Given this list of marker genes FGF6, RASSF7, SSH1, PAK4, CHRM2, VCL, FGF14, MYH10, MOS, MRAS, FGF13, BDKRB2, PIP4K2C, FGF21, FGF18, CHRM4, PIK3CD, MYL3, TMSB4X, PDGFRB, SOS1, PIP5KL1, SOS2, SSH3, PIP4K2A (NCBI Gene Id 5305), PAK1, RAC3, PIP5K1C, RRAS, WAS, KRAS, FGF8, MYLK, DIAPH3, MAP2K1, EZR, NRAS, RDX, ARHGEF7, PIK3R3 (phosphoinositide-3-kinase regulatory subunit 3), FGF20, CYFIP2, CFL1, PDGFB, CHRM5, ROCK2, ACTG1 (actin gamma 1), FGF17, MAPK1 (NCBI Gene Id 5594), ROCK1, ARHGAP35, PIK3R2, APC, WASF2, PAK3, PDGFRA, PIK3CG, VIL1, FGF4, GNA13, RAC1, PIK3R1 (phosphoinositide-3-kinase regulatory subunit 1), FGF5, GSN, PIK3CA, FGFR3, FGF10, PAK5, BDKRB1, WASF1, BRK1, CFL2, FGF3 (fibroblast growth factor 3), RAF1, RAC2, F2, GNA12, BAIAP2, FGF23, FGF22, CHRM1, FGD1, PXN, PIK3C2A, FGF16, ARHGEF1, CRK, FN1, NCKAP1, FGFR2, PIK3C2B, CHRM3, ACTB, PIP5K1A, CD14, MAP2K2, FGF1, GNG12, APC2, ENAH, PIK3CB, ARHGEF6, PTK2, PIK3C3, MAPK6 (NCBI Gene Id 5597), PAK6, F2R, BCAR1, CSK, EGF (epidermal growth factor), BUB1B-PAK6, FGF11, PFN1, FGF2, PDGFA, GIT1, PIK3R5 (NCBI Gene Id 23533), MSN (moesin), MAPK4, PAK2, DOCK1, PPP1R12A, IQGAP1, RRAS2, FGF12, PIK3C2G, ACTN1, PIP4K2B, FGFR4, SSH2, ARPC5, RHOA, ARHGEF4, PIK3R4 (phosphoinositide-3-kinase regulatory subunit 4), MAPK3, FGF19, FGFR1, PIP5K1B, LIMK1, CDC42, SLC9A1, FGF7, DIAPH1, VAV1, ITGA1, MYL1, FGF9, BRAF, ABI2, EGFR, here is a description of the gene set: Human Gene Set: WP_REGULATION_OF_ACTIN_CYTOSKELETON Regulation of actin cytoskeleton studied in species Homo sapiens